The following is a description of a gene set: Neighborhood of CBFB core-binding factor, beta subunit in the GCM expression compendium Human Gene Set: GCM_CBFB Neighborhood of CBFB species: Homo sapiens, and this is the list of marker genes: XPO1, ATP5F1B, PSMA5, TBCB, RBBP4, ILF2, SRSF9, TCEA1, NASP, SNRPD3, SNRPA, SNRPF, HMGN1, PCBP1, POLR2G, DUT, BRD8, ACAP2, PWP1, PPP1CC, SET, CAPRIN1, YWHAQ, ATXN10, NAP1L1, TRA2B, CAPZA1, POLG, BLMH, UBE2I (ubiquitin conjugating enzyme E2 I), SNRPE, HNRNPM, PSMA1, PFN1, NCL, MCM3, DDX18, YWHAZ, ACTG1, STMN1, HNRNPD, PSMA6, EIF3F, CBFB, NONO, ZNHIT3, HNRNPL, HNRNPU, HDAC1, COPS5, TP53, ARHGAP45, PSME1, SLC25A3, SLBP, SMC1A, DDX5, KHDRBS1, ESD, ACADM, APEX1, HPRT1, DHX9, SUMO2, ATP5PB, PPIA (peptidylprolyl isomerase A), ERH, CTCF (CCCTC-binding factor), NDUFA12, SRSF2